The following is a description of a gene set: Ultraviolet B irradiation initiates and promotes skin cancers, photo-aging, and immune suppression. In order to elucidate the effect of these processes at the level of gene expression, we used cDNA microarray technology to examine the effect of ultraviolet B irradiation on 588 cancer-related genes in human keratinocytes at 1, 6, and 24 h post-irradiation with a mildly cytotoxic dose of ultraviolet B (170 mJ/cm(2)). The viability of the irradiated keratinocytes was 75% at 24 h post-irradiation. Various cytokeratins and transcription factors were up-regulated within 1 h post-irradiation. After 6 h, expression of a variety of genes related to growth regulation (e.g. p21(WAF1), notch 4, and smoothened), apoptosis (e.g. caspase 10, hTRIP, and CRAF1), DNA repair (ERCC1, XRCC1), cytokines (e.g. IL-6, IL-13, TGF-beta, and endothelin 2), and cell adhesion (e.g. RhoE, and RhoGDI) were altered in human keratinocytes. These data suggest the changes in a cascade of gene expression in human keratinocytes occurring within 24 h after UVB exposure. Although the roles of these cellular genes after UVB-irradiation remain to be elucidated, microarray analysis may provide a new view of gene expression in epidermal keratinocytes following UVB exposure. studied in species Homo sapiens Genes down-regulated in primary keratinocytes at 24 h after UVB irradiation. Human Gene Set: MURAKAMI_UV_RESPONSE_24HR from publication Murakami T, Fujimoto M, Ohtsuki M, Nakagawa H (PMID 11532376), and this is the list of marker genes: DSG1, EDN2, DSP, EGR1, NOTCH4, TRAIP, MAP3K14, KRT1, RARG, IL6, TGFB1, SMO, RFC2, KRT10, DVL1 (NCBI Gene Id 348497, dishevelled segment polarity protein 1), VTN, IL13, IFI6, ITGB7, KRT14